Given this list of marker genes POMC, NAA50 (NCBI Gene Id 80218), DNASE2B, PRAMEF12, PLSCR1, INMT, SPRY1, HHIP, RAMP2, NR4A1, CDC42EP1, SLC12A7, SGMS2, SLC48A1, SELENOP, KLF9, FLT4, GPCPD1, CYSTM1, PI16, IFI27L2, SULT1A1, THBD, FMO1, ANKH, PLPP3, CFHR1, ZFP36L1, SIN3A, MGP, DCN, HES1, DUSP1, DSPP, MR1, ZCCHC9, TBX5 (T-box transcription factor 5), OAT, NOG, NR3C1, MUSTN1, CLEC3B, RORA, SMOC2, NFE2L2, BGLAP, CP, EPHX1, NGLY1, AMH, TWIST2, OMD, MFAP3L (NCBI Gene Id 9848), IGFBP7, IGFBP3, GSTZ1, SLC27A3, DOCK5, TRIM10, ASAH1, APOD, GLI1, SLC6A6, IGF1R, FEN1, RASSF3, GPC4, KLF4, FOXD1, PMP22, KLF10, BDNF, HEBP2, NKX2-5, TMEM140, FBN2, PLTP, ALX4, SLC35E3 (solute carrier family 35 member E3), LRMDA, FTL, RASSF8, FBN1, MAP3K1, ARHGEF10, ENPP1, POLA1, NID1, ABCD4, NCOA6, FILIP1L, BZW2, CMPK2, PTK7, IGFBP4 (NCBI Gene Id 3487), BMP5, TSPAN5, GPR155, CLVS1, GADD45A, CYP1B1, AKAP4, CCN2, PTCH1, KLB, H19, SERPINC1, PLAC8, RP9, PAICS, GRB14, DSCC1, OLFML2B, LEPROT, SOSTDC1, ABCA3, DPH6, MKNK2, ADD3, TSC22D3, SNX18, RPL29, PENK, UBE2J1, TEK, AKAP12, here is a description of the gene set: Genes up-regulated in 10T1/2 cells (multipotent mesoderma) by expression of SHH. Human Gene Set: INGRAM_SHH_TARGETS_UP studied in species Mus musculus Aberrant regulation of signalling mechanisms that normally orchestrate embryonic development, such as the Hedgehog, Wnt and Notch pathways, is a common feature of tumorigenesis. In order to better understand the neoplastic events mediated by Hedgehog signalling, we identified over genes regulated by Sonic Hedgehog in multipotent mesodermal cells. Widespread crosstalk with other developmental signalling pathways is evident, suggesting a complex network of interactions that challenges the often over-simplistic representation of these pathways as simple linear entities. Hes1, a principal effector of the Notch pathway, was found to be a target of Sonic Hedgehog in both C3H/10T1/2 mesodermal and MNS70 neural cells. Desert Hedgehog also elicited a strong Hes1 response. While Smoothened function was found necessary for upregulation of Hes1 in response to Sonic Hedgehog, the mechanism does not require gamma-secretase-mediated cleavage of Notch receptors, and appears to involve transcription factors other than RBP-Jkappa. Thus, we have defined a novel mechanism for Hes1 regulation in stem-like cells that is independent of canonical Notch signalling. from publication Ingram WJ, McCue KI, Tran TH, Hallahan AR, Wainwright BJ (PMID 17873912)